Given this list of marker genes Dnah11, Cfap53, Odad4, Dnah5 (NCBI Gene Id 170953), Cfap45, Enkur, here is a description of the gene set: A motile cilium where the axoneme has a ring of nine outer microtubule doublets but no central microtubules (and is therefore called a 9+0 axoneme). Mouse Gene Set: GOCC_9PLUS0_MOTILE_CILIUM studied in species Mus musculus